Given this list of marker genes SH2B3 (NCBI Gene Id 10019), MIR146A, SOCS3, SOCS1, PTPRD, GGNBP2, MIR340, INPP5F, NF2, SOCS2 (NCBI Gene Id 8835), PPARG, DAB1, MIRLET7E, ADIPOR1, MIR125B1, NEUROD1, LEPROT, MIR99A, CISH, MIR125A, CLEC12B, PIBF1, GBP7, PTPN2, PTPRC, HGS, VHL, HMGA2, MIR519A1, CAV1, MIR149, BCL3, PARP14, PTPRT, MIR9-1, MIR874, MIRLET7C, here is a description of the gene set: Human Gene Set: GOBP_NEGATIVE_REGULATION_OF_RECEPTOR_SIGNALING_PATHWAY_VIA_STAT studied in species Homo sapiens Any process that stops, prevents or reduces the frequency, rate or extent of receptor signaling via STAT.